The following is a description of a gene set: species: Homo sapiens from publication Jeffrey KL, Brummer T, Rolph MS, Liu SM, Callejas NA, Grumont RJ, Gillieron C, Mackay F, Grey S, Camps M, Rommel C, Gerondakis SD, Mackay CR (PMID 16474395) Human Gene Set: GSE3982_EFF_MEMORY_CD4_TCELL_VS_TH1_UP Genes up-regulated in comparison of effective memory CD4 T cells versus Th1 cells. In the present study we used Affymetrix oligonucleotide microarrays to produce gene transcription profiles for the major leukocyte types in humans. This comprehensive dataset enabled us to not only establish which genes were expressed in each leukocyte type, but also which genes were expressed in each subset after activation. The used of a comprehensive dataset of gene profiles from all the major human leukocyte subsets enabled a novel and powerful means for identification of genes associated with single leukocyte subsets, or different immune paradigms., and this is the list of marker genes: ANKS1B, SLC35E2B, SLC30A3, SCGB1D2 (secretoglobin family 1D member 2), PDLIM2, OR2B6, CPQ (NCBI Gene Id 51670), MARCHF8, ST8SIA1, GPR183, C1QTNF3, L1CAM, TSNAXIP1, SETD2, LAMA4, FOXO3, IL6R, LHB, AKT3, CFTR, OR1D2 (NCBI Gene Id 4991), CYB5R1, TPT1P8, NOTCH4, DBP, MYO5C, COL5A3, HNRNPA3, DLK2, C11orf21, N4BP2L1, ACSS3, TASOR (transcription activation suppressor), ZNF337, PLXNC1, LUC7L3, PRKACB, RALGPS1, RPL23AP32, SNTB1, HS3ST2, H3C12, CSRP3 (NCBI Gene Id 8048), LPIN1, PARP12, AK1, FBXO21, ELAC1, MPHOSPH9 (M-phase phosphoprotein 9), NDRG2, MYF5, PABPC3, GNAQ, BACH2, PLAC8, SOX13, IL25, TDRD3 (NCBI Gene Id 81550), TDRKH, AMPD2, PLXND1, SCYL3, CDC42BPB, TREH, NUPR1, ALDH7A1, RBMS3, NCK2, CCNJL, GMEB2, VPS52, GAD2, APOBR, ULK4, UIMC1, DPYD, ZNF446, XKR8, IRX4, SLC35C1, CD164, EEF1D, FLRT1 (NCBI Gene Id 23769), CD52, ZFP36L2, S100A14, TTC19, ALAS2, NHLH2, DOP1A, LPGAT1, IRAK4, CNR2, REG1B, C11orf71, PPM1F, MTMR1, TGFB2, MAGEA4, SPDEF, BTG1, HSD17B11, BTN2A1, MLLT3, FBXO40, SPACA9, GOLGA8A, PEX7, RPS17P5, ZSCAN26, DLX4, AKR1C1, BHLHE41, PCSK7, LUZP1, ZNF202, FAM8A1, SNCG, SPTLC3, TCF20, ARHGAP45, DCLK1, ADAMTS8, ENTR1, CD44, PDCD4 (programmed cell death 4), PPP1R12B, CBX2, CAMK4, QSER1, PDE10A, SCN8A, CEP162, PEPD, SLCO5A1, IFT122, SLC6A4, SULF1, PARM1, MORC4, GPR17, LY75, ARID4A, DCAF8, ARMCX5, PRMT2, INHBA, ADA2, SCRG1, CDH10, PBXIP1, AKAP8, KIF5A, ANXA1, CASP1, FLNB, CAPRIN2, VPS28, ZNF862, OR1F2P, DMWD, HECA, KCNN3, CDH4, ITIH4, UBE2D4, ZNF266, KBTBD2, SIRT3, ZBTB18, RPS6KA6, TRIM44, EPHX3, SRCAP, SLC34A1, RBM3, MYO16, BGN, SHBG, ZNF211, APBB3, AOAH, ZNF532, SMIM7, CAND2, EPPIN, LHPP, BIN1, IFT70A, OSBPL7, ISL1, LCT, DGKD, GHSR, RUFY1, NPIPB15, F8, SLN